The following is a description of a gene set: part of: Regulation of PD-L1(CD274) Post-translational modification Reactome Pathway: SPOP-mediated proteasomal degradation of PD-L1(CD274) electronically inferred by orthology from the curated human pathway studied in species Mus musculus This event has been computationally inferred from an event that has been demonstrated in another species.<p>The inference is based on the homology mapping from PANTHER. Briefly, reactions for which all involved PhysicalEntities (in input, output and catalyst) have a mapped orthologue/paralogue (for complexes at least 75% of components must have a mapping) are inferred to the other species., and this is the list of marker genes: Psma2, Csnk2b, Psmc2, Psmd13, Psmd6, Psma6 (NCBI Gene Id 26443), Psmc1, Psmd1, Psmc3, Psmc6, Ubb, Psma4, Psmb7, Rps27a, Psmb5, Psma1, Psmd7, Cd274, Psmb6, Psmb4, Cdk4, Psmd12, Psma7, Ccnd1, Psmc5, Psma3, Psma5, Psmc4 (proteasome (prosome, macropain) 26S subunit, ATPase, 4), Spop